The following is a description of a gene set: Regulation of T cell activation by CD28 family studied in species Mus musculus Mouse Gene Set: REACTOME_REGULATION_OF_T_CELL_ACTIVATION_BY_CD28_FAMILY, and this is the list of marker genes: Ctla4, Pdcd1lg2, Icos, Akt2, Mlst8, H2-Eb2, Rac1, Trav16, Cd247, Vav1, Cd28, Prr5, H2-Eb1, Trac, Fyn, Ptpn6, Pdcd1, Ppp2r5e (protein phosphatase 2, regulatory subunit B', epsilon), Trbv16, Lck, Ppp2r1b, Pak1, Mapkap1, Pik3r3, Pik3r5, Akt3, Ppp2r5a, Icosl, Yes1, H2-Aa, Pak3 (p21 (RAC1) activated kinase 3), Rictor, Grb2, Ppp2r5b, Ppp2ca, Cd86, H2-Ea, Pdpk1, Ppp2r5d, Cdc42, Pik3r6 (NCBI Gene Id 432574), Csk, Cd4, Cd274, Them4, Tnfrsf14, Trav19, Pik3r2, Ppp2cb, Ptpn11, Src, Pik3ca (phosphatidylinositol-4,5-bisphosphate 3-kinase catalytic subunit alpha), Map3k14, Trib3, Pak2, Ppp2r5c, Map3k8, Pik3cg, Pik3cd, Trbv15, Ppp2r1a, H2-Ab1, Grap2, Pik3r1, Mtor, Akt1, Cd3d, Cd80, Lyn, Cd3g, Pik3cb, Cd3e